The following is a description of a gene set: Human Gene Set: GSE18893_CTRL_VS_TNF_TREATED_TREG_2H_DN from publication Nagar M, Jacob-Hirsch J, Vernitsky H, Berkun Y, Ben-Horin S, Amariglio N, Bank I, Kloog Y, Rechavi G, Goldstein I (PMID 20181891) Genes down-regulated in T reg cells (2h): medium versus TNF. species: Homo sapiens Here we show that tumor necrosis factor (TNF) induced in human T-regulatory cells (Treg), as compared to conventional T cells (Tcon), a transcription program highly enriched for typical NF-κB target genes, such as: the cytokines LTA and TNF; the TNF-receptor super family members FAS, 4-1BB and OX-40; various anti-apoptotic genes; and other important immune-response genes. As an initial approach to examine the cellular program induced by TNF in Tregs versus Tcon cells, we employed microarray gene expression analysis at 2 and 24 hrs following TNF treatment., and this is the list of marker genes: TF (transferrin), RANBP9, LHX5, SIRT2, CCNO, A4GALT, SLC30A3, HERC6, SPSB1, SV2A, LAMP1, SPRY3, MYO1A, PPOX, ITCH, TMCO3, FURIN, RAB37, CPT2, RSAD2, OPN1SW, KRTAP15-1, KLF3, UBE2B, SPG11, AGT, RIMOC1, KLHDC8B, IL2RA, MORN1, RHOG, AVPR2, STC1, LMAN2L, MAP1LC3B, ROM1, C11orf71, CD3E, NAT8L, ORAI1, UBR5, TRPM1, ZFP36L1, MAN2A1, TMEM92 (NCBI Gene Id 162461), CCT8L2, OTOR, MYH9, UCKL1, MFSD6L (major facilitator superfamily domain containing 6 like), TMEM61, ARAP1 (ArfGAP with RhoGAP domain, ankyrin repeat and PH domain 1), NIPAL2, C12orf57, DYNC1I2, BATF2, CMYA5, ATP6V0D1, PLA2G5, MPP2, RBM18, EXD1, FAF2, IRF2, HAS2, FAM161A, MGST1, SERPINH1, CD99, ESM1, RBM38, SEM1, MROH1, HGD, ADGRE5, FBXO10, NPHS2, AP3M2, ANKRD13D, GAD1, ZNF319, ARF1, TRPC4 (transient receptor potential cation channel subfamily C member 4), NUDT7, PLEKHG3, KMT2E, PRICKLE3, SERPINB1, RALBP1, FAM53C, CLCN7, LSM14A, TMEM63B, GAK, NKIRAS2, MIR1915HG, HES3, AATK, SNX32, PGM2, FRAT1, LENG9, ZNF784, FNDC3B (NCBI Gene Id 64778), HAPSTR1, ZNF536, MUC5B, CCL13, ITPR2, DDO, SELENON, WEE2, CD180, EXOC1, NFAT5, USP47, PID1, CEMIP, MAF1, MED11, DEPDC1B, NAMPT, BTN1A1, BANK1, SQSTM1, CSF1, MLPH, PXK, CPLANE1, SPATA6, ARID5A, PRR14, CFAP69, MINDY3, FAM8A1, TMC4, PAXX, P2RX1, ACTN2, AIF1, VHL (NCBI Gene Id 8056), SIRT7, HTR1D, MYO1C, CNTN2, ACOT2, PRSS42P, UBTD1 (ubiquitin domain containing 1), ELF4, ARRB1, SCAMP2, ZNF236, SYT7, KLC1, CDK17, HEY1, DIO3OS, STX6, ST3GAL4, PROCA1, TMEM41B, NECAP1, FAM83F, YKT6, FAM163B, MARK4, TRAPPC6B, KCNE5, GPR75, FAM168A, HSPB9, UBL4B, TRIM5, GALC, PRXL2C, CADPS, FGF4, EVX1, RGP1, EGR3, RNF183, ITK, ZBTB7B, ZP3, MARCHF6, PIGZ, RNPEP, S1PR1, FUT7, ADGRV1, SMURF1, TIFAB, BMAL2, TAAR1, ADRB3, HSF5, ARRDC4, VAMP4, RNF38, RARA